The following is a description of a gene set: The acetylation of the N-terminal amino acid of proteins. studied in species Homo sapiens Human Gene Set: GOBP_N_TERMINAL_PROTEIN_AMINO_ACID_ACETYLATION, and this is the list of marker genes: KAT2B, NAA60, NAA10, NAA80, AANAT, NAA11, NAA20, CREBBP, NAA50, NAA16, EP300, NAA15